The following is a description of a gene set: studied in species Homo sapiens Pathway Definition from KEGG: LC3 -- ATG4 >> ATG7 >> ATG3 >> (ATG12+ATG5+ATG16L1) -> LC3-II Autophagy-vesicle nucleation/elongation/maturation, LC3-II formation. Pathway ID: N00156. Pathway type: Reference. Pathway class: nt06532 Autophagy. Human Gene Set: KEGG_MEDICUS_REFERENCE_AUTOPHAGY_VESICLE_NUCLEATION_ELONGATION_MATURATION_LC3_II_FORMATION, and this is the list of marker genes: ATG4B, ATG5, MAP1LC3C, MAP1LC3B2, ATG4C, MAP1LC3A, ATG7, ATG4A, ATG3, ATG12, MAP1LC3B, ATG16L1, ATG4D